Given this list of marker genes FGFR2, MAT2B, KCNH3, CHMP3, SLC30A3, CACNB3, RPH3A, CTNND1, WIPF3, ARPP19, PRKCZ, SYNGR3, TYRO3, FAM131A, CHN1, ACOT7, NEFL, PPP3CA, CALY, PPP1R1B, KIFC2, HBA2, here is a description of the gene set: from publication Johansson FK, Göransson H, Westermark B (PMID 15750623) Human Gene Set: JOHANSSON_GLIOMAGENESIS_BY_PDGFB_DN species: Mus musculus Retroviral tagging previously identified putative cancer-causing genes in a mouse brain tumor model where a recombinant Moloney murine leukemia virus encoding the platelet-derived growth factor B-chain (MMLV/PDGFB) was intracerebrally injected in newborn mice. In the present study, expression analysis using cDNA arrays revealed several similarities of virus-induced mouse gliomas with human brain tumors. Brain tumors with short latency contained on average 8.0 retroviral insertions and resembled human glioblastoma multiforme (GBM) whereas long-latency gliomas were of lower grade, similar to human oligodendroglioma (OD) and had 2.3 insertions per tumor. Several known and novel genes of tumor progression or cell markers were differentially expressed between OD- and GBM-like tumors. Array and quantitative real-time PCR analysis demonstrated elevated expression similar to Pdgfralpha of retrovirally tagged genes Abhd2, Ddr1, Fos, Ng2, Ppfibp1, Rad51b and Sulf2 in both glioma types compared to neonatal and adult normal brain. The retrovirally tagged genes Plekhb1, Prex1, Prkg2, Sox10 and 1200004M23Rik were upregulated in the tumors but had a different expression profile than Pdgfralpha whereas Rap1gap, Gli1, Neurl and Camk2b were downregulated in the tumors. The present study accentuates the proposed role of the retrovirally tagged genes in PDGF-driven gliomagenesis and indicates that insertional mutagenesis can promote glioma progression. Genes down-regulated in brain tumors induced by retroviral delivery of PDGFB.